The following is a description of a gene set: Any process that activates or increases the frequency, rate or extent of differentiation of regulatory T cells. species: Mus musculus Mouse Gene Set: GOBP_POSITIVE_REGULATION_OF_REGULATORY_T_CELL_DIFFERENTIATION, and this is the list of marker genes: Gimap5, Socs1, Bcl6, H2-Ea, Lilrb4a, Cd46, Tgfb1, Il2rg, Carmil2, Ifng, Klhl25, Lilrb4b, Foxo3, Vsir, Ambra1, Il2, Dusp10, Btn2a2, Gimap3, H2-M3 (histocompatibility 2, M region locus 3), Kat5, Lgals9, Sox12, Il4i1, Foxp3